The following is a description of a gene set: studied in species Homo sapiens The gene expression profile of peripheral Foxp3+ natural regulatory T cells isolated from Foxp3/EGFP bicistronic mice was compared to that of in vitro-induced regulatory T cells and to CD4+ conventional (Foxp3-) T cells. The role of the regulatory T cell transcription factor Foxp3 in shaping the transcriptosomes of natural and induced regulatory T cells was analyzed using mice expressing a mutant FOXP3-EGFP fusion protein (Foxp3deltaEGFP). We used gene expression microarrays to examine the transcriptional programs of natural and induced regulatory T cells and the function of Foxp3 in organizing the transcriptosomes of the respective cell type Genes down-regulated in natural T reg versus T conv. from publication Haribhai D, Lin W, Edwards B, Ziegelbauer J, Salzman NH, Carlson MR, Li SH, Simpson PM, Chatila TA, Williams CB (PMID 19265124) Human Gene Set: GSE14415_NATURAL_TREG_VS_TCONV_DN, and this is the list of marker genes: KIF14, RAD51C, SMC2, CDC25B, FOXE3, ACTB, MCM4, BIRC5, GSR, TPX2, SLC43A3, KNL1, PRC1, CALU, MIS18BP1, CENPF, LIG1, TRNP1, ITGAM, DUT, CHAF1B, LIX1L, NEIL3, CENPM, NAT8B, IGF2BP3, RAD51, KIF11, TTK, PRLR, WDHD1, MSN, FKBP5, CENPH, SPCS3, RAD54L, XRRA1 (X-ray radiation resistance associated 1), CDC45, SGO2, CEP55, UHRF1, BRCA1, RRM1, CENPE, ARHGAP11A, GINS1, CENPN, SYCE2, BLM, ITGAX, TAF1D, RRM2, MAD2L1, CDCA8, PAX1, ROM1, ZBP1, NDC80, AGFG2, HMGB2, HOXB2, FBXO5, USP46, STMN1, GZMK, ASF1B, DLGAP5, OSBPL3, PLK1, NCAPD2, EHBP1L1, CKAP2L, ANP32B, SCAF1, CTSD, ESCO2, CHTF18, CDKN3, PALM, CENPP, TK1, IQGAP3, NEUROD4, TACC3, DISP3, CKM, CBX5, TEAD3, DISP2, MCM5, ZBTB32, FIBCD1, ANXA4 (NCBI Gene Id 307), HNRNPA3, PBK, MYBL1, CORO2A, MYL4, GNAI2, HMMR, LMNB1, PMF1, CNIH2, MTTP, ADSS1, E2F8, KCNK2, PTMS (parathymosin), CHEK1, MX2, CKAP2, MCM3, NRTN, HCLS1, KIF23, H1-5, NCAPG, KIF4A, ARHGAP19 (Rho GTPase activating protein 19), MCM2 (minichromosome maintenance complex component 2), ASXL1, HNF4A, CDC25C, MAPK1, DHCR24, EDN3, ATP2A2, MTR, CDK1, LRR1, KDM4A, SPN, ABR, KIF15, MTCH1, HIP1, RAB39A, NSMF, HELLS, PYCARD, MRPL34, CLSPN, VIM, AURKA, ARF6, USP3, NCKIPSD, GPR55, BRIP1, GZMA, CALHM4, CDCA3, NCAPH, ABCF1, GZMB, MCM7, CENPS, TOPBP1, PRR11, LSP1, RNASEH2B, CCNB2, SPAG5, TOP2A, HNRNPUL1, ASPM (assembly factor for spindle microtubules), LAMC1, SLC41A3, CCNA2, FKBP2, CTSC, SGO1, BUB1B, CKS1B, BUB1, NUF2, FAM117A, PDLIM4, SPC24, PTGR1